The following is a description of a gene set: species: Mus musculus This event has been computationally inferred from an event that has been demonstrated in another species.<p>The inference is based on the homology mapping from PANTHER. Briefly, reactions for which all involved PhysicalEntities (in input, output and catalyst) have a mapped orthologue/paralogue (for complexes at least 75% of components must have a mapping) are inferred to the other species. Reactome Pathway: Collagen degradation electronically inferred by orthology from the curated human pathway part of: Degradation of the extracellular matrix, and this is the list of marker genes: Col11a2, Tmprss6, Col8a2, Col6a1, Mmp10, Phykpl, Col4a2, Col4a5, Mmp20, Col12a1 (NCBI Gene Id 12816), Col2a1, Mmp3, Col13a1, Mmp2, Col10a1, Col25a1, Mmp12, Col18a1, Mmp11, Mmp8, Mmp13, Mmp7, Col6a6, Ctsd, Col7a1, Col8a1, Col6a5, Col19a1, Col5a3, Mmp15, Col15a1, Col4a6, Mmp14